Given this list of marker genes ASB13, MDM2, WASHC2A, RHBDL2, RPS6KA3, SMC4, SLFN13, SPATA6, TAOK1, SLC20A1, TMEM87B, CST7, SERPINC1, PDLIM1, PTTG1, SIT1, TNKS1BP1 (tankyrase 1 binding protein 1), FCGRT, SLC39A14, PAF1, ZNF511, NRXN1, TMEM63A, IKBKB, VPS13D, POMT2, MRAP2, RBM48, FGD3, TMEM42, NSUN4, PI4KA, PDCD6, TRIP12, PLEC, ITPKC, REXO4, IRF7, YWHAB, RNF167, STOML1, TES, IGSF11, VPS26B, ATP6V1F, ANAPC16, SUPT4H1, MRPS26, GRAMD1B, CCNL2, EIF4A2, RHOA, CEP135, MOB2, SAMD9L, PARP3, GPR183, REXO5, ARMC10, TOMM34, ITGB2, CCND2, IFIT1B, GPR63, SLA2, STAT1, SDR39U1, PLEKHA2, CYBA, MCMBP, CMIP, TAOK3, RPLP2, DCTN6, CD38, TMEM243, ZNF7, PIAS4, GPATCH2, ARPC5, SLC30A1, STX5, SMYD4 (SET and MYND domain containing 4), AEBP2, AMN1, PRXL2C, GNPTG, EIF3E, AMBRA1, FIS1, MAN2A1, ABCG1, PRDM2, CSNK2A1, PPARGC1B, GSTT2, SERBP1, RPRD2, COMMD6, PYGB, TBX6, CAMK2B, MSS51, MARVELD2, ZNF354C (NCBI Gene Id 30832), STMN3, COL15A1, GABRR2, TOMM7, MED28, CATSPERD, BABAM1, CD82, ARL5A (NCBI Gene Id 26225), RPL27, SP1, CUL3 (NCBI Gene Id 8452, cullin 3), ORAI1 (NCBI Gene Id 84876), TNRC18, PKD1, OSTM1, PTPRC, TNFAIP1 (NCBI Gene Id 7126), PDLIM5, JPT1, ITGAL, AP3M2, C16orf90 (NCBI Gene Id 651035), MARK2, FAM120B, PDE4DIP, RANBP9, TMEM241, IP6K1, PAPPA2, ANKIB1, RLF, LRP10 (NCBI Gene Id 26020), RNF123, CHIC2, ARK2C, CIC, PSME1, CACNG2, RBM22, RTP4, TRIM5, DEGS1, RALA, RASL11B, RIGI (RNA sensor RIG-I), AFG2B, MBNL1, LPXN, PDCD1, PLEKHA7, SF3B2, MAL, NMI, PDE7A, NABP1, PPM1B, TMOD3, EIF3K, FOXJ2, CRBN, RAB24, ARFRP1, MAP3K2, EFR3A, PTPRCAP, RBM10, KRAS, PLTP, LEP, ITM2A (NCBI Gene Id 9452), TM9SF3, NUP210, TEX264 (testis expressed 264, ER-phagy receptor), ERP27, MALAT1, NFATC2, LYST, MTIF3, VAMP4, RASSF7, ATP1B1, AKR1B1, POGZ, PIP5K1A, NLRC5, WDR26, ESCO1, CSNK1G2, ITPK1, CEPT1, SOCS3, RIMOC1, ATP6V0A2, EEF1G, here is a description of the gene set: Human Gene Set: GSE27786_LIN_NEG_VS_CD8_TCELL_DN Genes down-regulated in comparison of lineage negative versus CD8 T cells. Each fraction of mouse hematopoietic cells was purified by cell sorting from bone marrow of 8-week-old C57BL/6 mice, and its gene expression was analyzed. studied in species Homo sapiens from publication Konuma T, Nakamura S, Miyagi S, Negishi M, Chiba T, Oguro H, Yuan J, Mochizuki-Kashio M, Ichikawa H, Miyoshi H, Vidal M, Iwama A (PMID 21540074)